Given this list of marker genes HOXA9, TBXT, SFRP4, C1D, ALKAL2, HNRNPU, CCNB1, LINC00623, CAVIN2, RGS17, PEDS1, RNU4-2, GPR82, CNMD, CCDC39, WBP4, IGLV5-52, CLHC1, TPH1, ARL17A, ATG10, PHOSPHO2, NPIPA7, here is a description of the gene set: Human Gene Set: HOEK_NK_CELL_2011_2012_TIV_ADULT_3DY_UP species: Homo sapiens Genes up-regulated in natural killer cell 3d vs 0d in adults after exposure to 2011-2012 trivalent inactivated vaccine (A/California/7/09 (H1N1), A/Perth /16/2009 (H3N2), B/Brisbane/60/2008), time point 3D. Comment: Up-regulated DE RNA transcripts (up >= 1.5x) shared between both TIV-vaccinated donors from publication Hoek KL, Samir P, Howard LM, Niu X, Prasad N, Galassie A, Liu Q, Allos TM, Floyd KA, Guo Y, Shyr Y, Levy SE, Joyce S, Edwards KM, Link AJ (PMID 25706537) Systems biology is an approach to comprehensively study complex interactions within a biological system. Most published systems vaccinology studies have utilized whole blood or peripheral blood mononuclear cells (PBMC) to monitor the immune response after vaccination. Because human blood is comprised of multiple hematopoietic cell types, the potential for masking responses of under-represented cell populations is increased when analyzing whole blood or PBMC. To investigate the contribution of individual cell types to the immune response after vaccination, we established a rapid and efficient method to purify human T and B cells, natural killer (NK) cells, myeloid dendritic cells (mDC), monocytes, and neutrophils from fresh venous blood. Purified cells were fractionated and processed in a single day. RNA-Seq and quantitative shotgun proteomics were performed to determine expression profiles for each cell type prior to and after inactivated seasonal influenza vaccination. Our results show that transcriptomic and proteomic profiles generated from purified immune cells differ significantly from PBMC. Differential expression analysis for each immune cell type also shows unique transcriptomic and proteomic expression profiles as well as changing biological networks at early time points after vaccination. This cell type-specific information provides a more comprehensive approach to monitor vaccine responses.